The following is a description of a gene set: Mouse Gene Set: BURTON_ADIPOGENESIS_PEAK_AT_2HR studied in species Mus musculus Cluster 2: genes maximally expressed at 2 h time point during differentiation of 3T3-L1 fibroblasts into adipocytes (cluster 2) in response to adipogenic hormones. from publication Burton GR, Guan Y, Nagarajan R, McGehee RE Jr (PMID 12137940) The molecular mechanisms that regulate cellular differentiation during development and throughout life are complex. It is now recognized that precise patterns of differentially expressed genes ultimately direct a particular cell toward a given lineage and many of these are regulated during the earliest stages of differentiation. Using a microarray-based expression analysis, we have examined gene expression profiles during the first 24 h of 3T3-L1 adipocyte differentiation. RNA was isolated at times 0, 2, 8, 16, and 24 h following stimulation of differentiation and hybridized in duplicate to high density Affymetrix microarray gene chips containing a series of 13,179 cDNA/expressed sequence tag (EST) probe sets. Two hundred and eighty-five cDNA/ESTs were shown to have at least a fivefold change in expression levels during this time course and both hierarchical and self-organizing map clustering analysis was performed to categorize them by expression profiles. Several genes known to be regulated during this time period were confirmed and Western blot analysis of the proteins encoded by some of the identified genes revealed expression profiles similar to their mRNA counterparts. As expected, many of the genes identified have not been examined in such a critical time period during adipogenesis and may well represent novel adipogenic mediators., and this is the list of marker genes: Cxcl1, Cebpd, Rhoj, Il6, Adm, Ccn2, Emd (emerin), Klf4, Foxc2, Dnajb4, Lonp1, Ccn1, Hk2, Dusp1, Phlda1, Serpine1, Tnfrsf1b, Id3, Cdr2l, Rgs2, Myc, Cdr2, Btg2, Junb, Thbs1, Zfp36, Ier3, Rhob, Capn1, Map2k3, Ptgs2, Nr4a2, Fosb, Bag3, Fos, Ackr3, Gm36287, Errfi1, Tnfaip6, Dnajb6, Gadd45g, Sema3c, Slc20a1, Ppp1r15a, Nr4a1, Ets2 (NCBI Gene Id 23872), Dnajb1